Given this list of marker genes Yeats4, Tfap2a, Cited1, Tfap2c, Cited2, Tfap2b (transcription factor AP-2 beta), Ep300, Wwox, Cited4, Tfap2e, Tfap2d, here is a description of the gene set: Activation of the TFAP2 (AP-2) family of transcription factors studied in species Mus musculus Mouse Gene Set: REACTOME_ACTIVATION_OF_THE_TFAP2_AP_2_FAMILY_OF_TRANSCRIPTION_FACTORS